The following is a description of a gene set: species: Homo sapiens Any process in which a protein is transported to, and/or maintained at the adherens junction. Human Gene Set: GOBP_PROTEIN_LOCALIZATION_TO_ADHERENS_JUNCTION, and this is the list of marker genes: MPP7, TJP1, ACTB, SCRIB, DLG5, VCL, DSG3